The following is a description of a gene set: Reactome Pathway: Translocation of ZAP-70 to Immunological synapse part of: TCR signaling The dual phosphorylated ITAMs recruit SYK kinase ZAP70 via their tandem SH2 domains (step 8). ZAP70 subsequently undergoes phosphorylation on multiple tyrosine residues for further activation. ZAP70 includes both positive and negative regulatory sites. Tyrosine 493 is a conserved regulatory site found within the activation loop of the kinase domain. This site has shown to be a positive regulatory site required for ZAP70 kinase activity and is phosphorylated by LCK (step 9). This phosphorylation contributes to the active conformation of the catalytic domain. Later ZAP70 undergoes trans-autophosphorylation at Y315 and Y319 (step 10). These sites appear to be positive regulatory sites. ZAP70 achieves its full activation after the trans-autophosphorylation. Activated ZAP70 along with LCK phosphorylates the multiple tyrosine residues in the adaptor protein LAT (step 11). PTPN22 can dephosphorylate and inhibit ZAP70 activity to downregulate TCR signaling (step 12). species: Homo sapiens, and this is the list of marker genes: TRAV19, HLA-DRA, TRBV7-9, HLA-DRB1, HLA-DRB3, HLA-DQA1, HLA-DQA2, ZAP70, CD4, TRBV12-3, CD3G, CD3E, HLA-DQB2, HLA-DRB4, TRAV29DV5, PTPN22, HLA-DPB1 (major histocompatibility complex, class II, DP beta 1), TRAV8-4, HLA-DPA1, TRAC, CD247, TRBC1 (NCBI Gene Id 28639), LCK, HLA-DQB1, CD3D, HLA-DRB5 (NCBI Gene Id 731247)